Given this list of marker genes MCMDC2, RAD51, RAD52, DMC1, RAD51C, here is a description of the gene set: species: Homo sapiens Human Gene Set: GOBP_DNA_REPAIR_COMPLEX_ASSEMBLY The aggregation, arrangement and bonding together of a set of components to form a DNA repair complex.